The following is a description of a gene set: Human Gene Set: WP_MITOCHONDRIAL_FISSION_AND_FUSION Mitochondrial fission and fusion species: Homo sapiens, and this is the list of marker genes: SH3GL2 (SH3 domain containing GRB2 like 2, endophilin A1), MTFP1, BCL2L1, FIS1, BNIP3, PLD1, PHB1, MIB1, MFN1, MFN2, OPA1, BAX, DNM1L